Given this list of marker genes DYNAP, GJB4, C14orf39, TNNT2, GPR149, IL2RG, RGS16, MMD, JAG1, ST3GAL6, HTRA1, KHDRBS3, PLA2G7, SYCP3, NPPB, CHD7, VCAM1, NRP2, ACKR3, here is a description of the gene set: Human Gene Set: LIN_TUMOR_ESCAPE_FROM_IMMUNE_ATTACK Genes up-regulated in highly immune-resistant cancer cell line developed from a susceptible cancer using an in vivo selection strategy. species: Mus musculus Immune escape is an important reason why the immune system cannot control tumor growth, but how escape variants emerge during immunotherapy remains poorly understood. Here, we identify a new mechanism of tumor immune escape using an in vivo selection strategy. We generated a highly immune-resistant cancer cell line (P3) by subjecting a susceptible cancer cell line (P0/TC-1) to multiple rounds of in vivo immune selection. Microarray analysis of P0 and P3 revealed that vascular cell adhesion molecule-1 (VCAM-1) is up-regulated in the P3-resistant variant. Retroviral transfer of VCAM-1 into P0 significantly increased its resistance against a vaccine-induced immune response. Analysis of tumors showed a dramatic decrease in the number of tumor-infiltrating cluster of differentiation 8(+) (CD8(+)) T cells in the tumors expressing VCAM-1. In vitro transwell migration assays showed that VCAM-1 can promote the migration of CD8(+) T cells through its interaction with the alpha(4)beta(1) integrin. Site-directed mutagenesis of VCAM-1 at amino acid residues required for interaction with alpha(4)beta(1) integrin completely abolished the immune resistance conferred by VCAM-1 in vivo. Surface staining showed that most renal cell carcinomas (RCC) express VCAM-1, whereas an RCC that responded to vaccination was VCAM-1 negative. These data provide evidence that tumor expression of VCAM-1 represents a new mechanism of immune evasion and has important implications for the development of immunotherapy for human RCC. from publication Lin KY, Lu D, Hung CF, Peng S, Huang L, Jie C, Murillo F, Rowley J, Tsai YC, He L, Kim DJ, Jaffee E, Pardoll D, Wu TC (PMID 17308126)